The following is a description of a gene set: species: Mus musculus This event has been computationally inferred from an event that has been demonstrated in another species.<p>The inference is based on the homology mapping from PANTHER. Briefly, reactions for which all involved PhysicalEntities (in input, output and catalyst) have a mapped orthologue/paralogue (for complexes at least 75% of components must have a mapping) are inferred to the other species. Reactome Pathway: Acyl chain remodelling of PG part of: Glycerophospholipid biosynthesis electronically inferred by orthology from the curated human pathway, and this is the list of marker genes: Pla2g12a, Pla2g4f, Lpcat4 (NCBI Gene Id 99010), Pla2g2f, Pla2r1, Pla2g1b, Pla2g3 (phospholipase A2, group III), Pla2g2a, Pla2g2d, Pla2g5, Pla2g4d, Pla2g2e